The following is a description of a gene set: Binding to ubiquinone, a quinone derivative with a tail of isoprene units. species: Homo sapiens Human Gene Set: GOMF_UBIQUINONE_BINDING, and this is the list of marker genes: COQ10A, ETFDH, COQ10B, SDHB, MT-ND4 (mitochondrially encoded NADH:ubiquinone oxidoreductase core subunit 4), SDHD